The following is a description of a gene set: studied in species Mus musculus Genes down-regulated in 3T3-L1 cells (fibroblast) induced to differentiate to mature adipocytes and then treated with a TZD derivative AD-5075, a PPARG activator. from publication Gerhold DL, Liu F, Jiang G, Li Z, Xu J, Lu M, Sachs JR, Bagchi A, Fridman A, Holder DJ, Doebber TW, Berger J, Elbrecht A, Moller DE, Zhang BB (PMID 12021175) Human Gene Set: GERHOLD_RESPONSE_TO_TZD_DN PPAR gamma is an adipocyte-specific nuclear hormone receptor. Agonists of PPAR gamma, such as thiazolidinediones (TZDs), promote adipocyte differentiation and have insulin-sensitizing effects in animals and diabetic patients. Affymetrix oligonucleotide arrays representing genes were employed to profile the gene expression responses of mature 3T3-L1 adipocytes and differentiating preadipocytes to a TZD PPAR gamma agonist in vitro. The expression of genes was significantly up- or down-regulated by more than 1.5-fold during differentiation and/or by treatment with TZD, and these genes were organized into 32 clusters that demonstrated concerted changes in expression of genes controlling cell growth or lipid metabolism. Quantitative PCR was employed to further characterize gene expression and led to the identification of beta-catenin as a new PPAR gamma target gene. Both mRNA and protein levels for beta-catenin were down-regulated in 3T3-L1 adipocytes compared with fibroblasts and were further decreased by treatment of adipocytes with PPAR gamma agonists. Treatment of db/db mice with a PPAR gamma agonist also resulted in reduction of beta-catenin mRNA levels in adipose tissue. These results suggest that beta-catenin plays an important role in the regulation of adipogenesis. Thus, the transcriptional patterns revealed in this study further the understanding of adipogenesis process and the function of PPAR gamma activation., and this is the list of marker genes: PPARG, CEBPD, PMP22, SOX4, MCL1, APOE, CXCL12, AGT, CRYAB, CD81, GHR, CFD, MNT